The following is a description of a gene set: Mouse Gene Set: GOBP_HORMONE_TRANSPORT The directed movement of hormones into, out of or within a cell, or between cells, by means of some agent such as a transporter or pore. studied in species Mus musculus, and this is the list of marker genes: Il1rn, Acvr2a, Epha5, C1qtnf12, Rptor, Hmga1, Ucn, Prkcb, Ffar1, Rab11fip2, Slc17a4, Nucb2, Fto, Gabbr1, Nkx6-1, Gnao1, Fgg, Htt, Ptger4, Mir410, Chd7, Trpm2, Nos1, Pax8, Cltrn, Slc16a10, Doc2b, Myb, Rab11fip3, Gck, Il6, Stim1, Rab11b, Snap25, Itsn1 (intersectin 1 (SH3 domain protein 1A)), Pfkm, Pla2g6, Hadh, Ptprn, Pde1c, Mup2, Kcnj6, Gal, C1qtnf3 (NCBI Gene Id 81799), Rab44, Slc16a2, Mup5, Foxd1, Pim3 (NCBI Gene Id 50885), Arhgef7, Snord33, Gper1, Fkbp1b (NCBI Gene Id 14226), Jagn1, Creb1, Pde3b, Prkce, Sidt2, Gipr, Ptger3, Ucn2, Tiam1, Slc18a2, Pick1, Edn2, Abcc2, Bmp6, Tmf1, Mir130a, Lep, Syt7, Rest, F2rl2, Aqp1, Ifng, Tubb1, Snx4, Midn, Lif, Smad4, Ecrg4, Glud1, Ptpn11, Tm7sf3, Lrp1, Adipoq, Cyb5r4, Snap23, Slc25a22, Nnat, Rapgef4, Neurod1, Rbm4, Edn3 (NCBI Gene Id 13616), Mafa (NCBI Gene Id 378435), Ptpmt1, Sox4, Anxa7, Bad, Kdm5b, Slc9b2, Htr2c, Ywhaz, Fgfr1, Orai1, Mir200a, Mup11, G6pc2, Foxa2, Gpr68, Clcf1, Vamp2, Vsnl1, Inhba, Ghrhr, Alox5, Ptprn2, Sox11, Rab8b, Mup1, Ndufaf2, Fbn1, Mpc2, Cpt1a (carnitine palmitoyltransferase 1a, liver), Fam3a, Drd2, Ano1, Foxl2, Hcfc1, Hmgcr, Gja1, Ccn3, Aacs, Cacna1d, Abcb1a, Egfr, Grp, Mtnr1a, Cacna1c, C1qtnf1, Capn10, Psmd9, Mtnr1b, Srebf1, Mcu, Npff, Acsl4, Smpd3, Tcf7l2, Cckar, Inha, Fam3d, Tbx3, Fgfr4, Sytl4, Adora3, Gnaz, Snord34, Tspo, Per2, Abcg1, Trpa1, Gnaq (NCBI Gene Id 71788), Slc16a1, Nell2, Snx19, Rbp4, Pfkfb2, Slc8b1, Nmb, Blk, Kcnb1, Ptbp1, Mc4r, Chrm3, Vamp8, Isl1, Adcy8, Apln, Tnfsf11, Adcyap1, Slco1c1, Pde4c (phosphodiesterase 4C, cAMP specific), Lrp5, Cyp19a1, Stxbp3, Cplx3, Klf7, Cnr1 (NCBI Gene Id 12801), Rfx3, Rab11fip1, Irs1, Trpc1, Tunar, Lepr, Adora1, Rab1a, Nadk, Ffar2, Oprm1, Prkn, Rph3al, Ren1, Nmu, F2, Ncoa6, Pomc, Myt1, Sfrp1, Hmga2, Cdk16, Plcb1, Ffar4, Agtr1a, Sybu, Kiss1, Cpe, Kcnj11, Baiap3, Stx1a, Tfr2, Anxa1, Tfap2b, Pask, Abca12, Nos2, Ensa, Niban2, Mup4, Cartpt, Inhbb, Oprk1, Ppp3ca, Sstr5, Atg7, Ptprv (protein tyrosine phosphatase receptor type V), Eipr1, Ucp2, Gna11, Nrg1, Agtr2, Trpm5 (NCBI Gene Id 56843), Kcnq1, Zbed6, Gdf9, Pex5l, Sirt4, Crhr2, Rab11fip5, Adcy5, Uqcc2, Oxct1, Rfx6, Smad2, Jak2, Ppp3cb, Gprc6a, Exoc3l, Vdr, Ccl5, Crhbp, Gata3, Birc5, Scg5, Slc2a2, Bmal1, Gpr119, Cntf, Sirt1, Trpv6, Igfbp3, Lyn, Edn1, Rasl10b, Kif5b, Pde8b, Irs2, Gnas, Adra2a, Pclo, Pla2g3, Aimp1, Snord35a (NCBI Gene Id 27211), Tbc1d1, Htr1a, Tcirg1, Bglap2, Park7, Pck2, Slc3a2, Gcg, Ghrh, Pparg, Tnf, Serpina7, Ppard, Ube2q1, Btk, Chga, Myo5a, Cry1, Madd, Ildr2, Nppa, Itpr1, Hfe, Eny2, Glul, Vgf, Rac1, Gip, Npy1r, Map4k4, Ffar3, Syt9, Nkx3-1, Anxa5, Mfn2 (mitofusin 2), Gnai1, Sirt3, Hnf1a, Snord32a, Agt, Abcc8, Prkaca, Myh9, Hnf1b, Cyp2j5, Sirt6, Selenom, Mlxipl, Foxo1, Fgb, Rims2, Ildr1, Oga, Piwil4, Stxbp4, Prkar1a, Camk2n1, Gpr39, Cacna1e, Dio2, Selenot, Abat, Galr1, Acvr1c, Ghsr, Vip, Uts2, Clock, Pdx1, Rab3a, Hcar2, Cftr, Glp1r, Lrrc8a, Cplx1, Spp1, Nr1h4, Cask, Ghrl, Prkd1, Cry2, Crhr1, Slc7a8, Cela2a, Efna5, Hnf4a, C2cd2l, Runx1, Fzd4, Fgf23, Hmgn3, Trpv4, Tacr2, Tacr1, Nr1d1, Dynll1, Trpm4, Crym, Cckbr, Wnk4, Ucn3, Npvf, Hif1a, Ccdc186, Il1b, Myrip, Cga, Sri, Gpr27, Stxbp5l, Trh, Retn, Arrb1, Slc30a8, Gpld1, Il11, Crh, Acvr2b, Raf1, Casr, Serp1, Dgat1, Stx4a, Osbp, Ltbp4, P2ry1, Fga, Nlgn2, Pfkl, Slc7a5, Kcnk9, Tac1, Tardbp, Osm, Fam3b, Kiss1r, Brsk2, Mup3 (major urinary protein 3), Kalrn, Sct (secretin), F2rl1, Dab2, Cyp27b1, Nr0b2, Cd38 (CD38 antigen)